Given this list of marker genes ELP3, USP44, GATAD2A, GCM2, HK1, LAP3, TMEM104, NUTF2, SGSM1, TIMM13, NEFH, IKZF3, GTF2A1, PLXDC2, NANS, CASS4, RDH13, TWF1, CLSTN1, BHMT, THG1L, XK, RIPK2, COQ7, TCF3 (transcription factor 3), TMEM97, OBSCN, STIMATE, MOXD2P, SH3RF2, ALAD, SCLY, DUSP6, SYT9 (NCBI Gene Id 337992, synaptotagmin 9), CYP2W1, DCP2, ST6GALNAC4, RPIA, ACOXL, DMWD, ANKRD55, KCNG3, MAB21L1, GPX8, SLC39A3, IL12RB1, FAM20B, SLC46A3, GZMA, TAPBPL, CAV3, OTP, LAMB3, DDB1, KATNB1, SLC22A9, FBXL7, KPNB1, ACBD4, KIF2B, TMEM120A, ITGB1, ADAM19, KLHL1, GTF2B, HRCT1, ACTR1B, FOXA2, ZBTB38, PGLYRP3 (peptidoglycan recognition protein 3), STIM2, PSMD7, MED25, LRRK1, PLG, LPCAT4, NADSYN1, EFHD2 (NCBI Gene Id 79453), NRP1, USP5, DNPEP, DCLK1, TEX101, CAD, PSMD3 (proteasome 26S subunit, non-ATPase 3), MED24, G3BP1, PPFIBP2, PPL, CDC45, NEUROD6, ELMO2, TMEM184A, PSMB5, KYAT3, BOK, FAM185A, METRN, CD7, ARMC1, TKT, MEG3, ZFPM1, CCDC3, C1RL, PTPN23, CASP1, FUT1, HAX1, ANXA1, DOLPP1, ENTPD1, TMEM171, SDHB, CNPY1, HEATR5B, LRP10, DCLRE1B, GFOD1, PLCB3, DCAF15, LRRC43, WFDC13, TMPRSS12, CARMIL1, SLCO4A1, SLC26A9, NHP2, CACNG8, ABCF1, CLTC, STX18, HAUS7, GFI1, PTP4A3, ENTPD4 (ectonucleoside triphosphate diphosphohydrolase 4), FGF13, RNF126, GAS7, RAVER2, P2RX5, NUDT15, ADSL (NCBI Gene Id 158), ANKRD52, SLC48A1, MT3, PUS10 (pseudouridine synthase 10), TTC7B, NCOA1, ONECUT2, DENR, LMO4, TMPRSS3, COL9A1, PKIG, RPA2, CLCA3P, FOXA1, UGCG, CYB561, PDCD1LG2, ABCF2, LPIN2, NAT1, TSFM, PPP1R14B, here is a description of the gene set: studied in species Homo sapiens IFNs are highly pleiotropic cytokines also endowed with marked anti-angiogenic activity. In this study, the mRNA expression profiles of endothelial cells (EC) exposed in vitro to IFN-alpha, IFN-beta, or IFN-gamma were determined. We found that in HUVEC as well as in other EC types genes were upregulated (>2-fold increase) by IFNs, including genes involved in the host response to RNA viruses, inflammation, and apoptosis. Interestingly, genes showed a >5-fold higher induction by IFN-alpha in EC compared to human fibroblasts; among them, the gene encoding the angiostatic chemokine CXCL11 was selectively induced by IFN-alpha in EC along with other genes associated with angiogenesis regulation, including CXCL10, TRAIL, and guanylate binding protein 1 (GBP-1). These transcriptional changes were confirmed and extended by quantitative PCR analysis and ELISA; whereas IFN-alpha and IFN-beta exerted virtually identical effects on transcriptome modulation, a differential gene regulation by type I and type II IFN emerged, especially as far as quantitative aspects were concerned. In vivo, IFN-alpha-producing tumors over-expressed murine CXCL10-11, GBP-1 and TRAIL, with evidence of CXCL11 production by tumor-associated EC. Overall, these findings improve our understanding of the anti-angiogenic effects of IFNs by showing that these cytokines trigger an anti-angiogenic transcriptional program in EC. Moreover, we suggest that quantitative differences in the magnitude of the transcriptional activation of IFNresponsive genes could form the basis for cell-specific transcriptional signatures. from publication Indraccolo S, Pfeffer U, Minuzzo S, Esposito G, Roni V, Mandruzzato S, Ferrari N, Anfosso L, Dell'Eva R, Noonan DM, Chieco-Bianchi L, Albini A, Amadori A (PMID 17202376) Genes up-regulated in fibroblasts: untreated versus IFNG. Human Gene Set: GSE3920_UNTREATED_VS_IFNG_TREATED_FIBROBLAST_UP